The following is a description of a gene set: Mouse Gene Set: ZBTB24_TARGET_GENES from publication Yevshin I, Sharipov R, Kolmykov S, Kondrakhin Y, Kolpakov F (PMID 30445619) species: Mus musculus Genes containing one or more binding sites for (Zbtb24) in their promoter regions (TSS -1000,+100 bp) as identified by GTRD version 20.06 ChIP-seq harmonization., and this is the list of marker genes: Alox5ap, Gm13134, Orc4, Rnf187, Zfp385b (zinc finger protein 385B), Amn, Rpl32, Tmem192, Plekhd1, Plin2, Slc25a44, Tuft1, Dnmt3a, Wasf1, Arid5b, Cnpy4, D030040B21Rik, Slc27a5, Dtnb, Prox1, Mbd5, Phf5a, Cdca7, Snx15 (NCBI Gene Id 69024), Synpo, Ostc, Axin2, Aldh2, Ccdc13, Pag1, Cdc40, Hmbs (NCBI Gene Id 97580), H2-Q7, Trim44, Taf6, Nfyc, Dlgap4, Pax8, Idh1, Emid1, Prepl, Hgfac, Gstz1, Pikfyve, Eml2, Btnl10, Chadl, Eloc, Slc18a3, Camkmt, Setd4, Zfp57, Spaca9, Ift27 (NCBI Gene Id 67042), Aco2, Rbl2, 9130017K11Rik, Anapc5, Mertk, Snora7a, Ak8, Wapl, Gm20716, Plekhd1os, Phox2a, Zfp507, Dlg5, Fut10, Mad2l1, Usp43, Zbtb6, Epn3, Hlx, Selenow, Mmd2 (NCBI Gene Id 97274), Crebbp, Igfbp2, Sinhcaf, Mgst1, Zfp563, Rassf3, Suox, Fcho2, Acsf3, Dpm1, Arhgap33os, Dcaf10